The following is a description of a gene set: from publication Chen Y, Wang X (PMID 31504780) species: Mus musculus Mouse Gene Set: MIR_487B_3P Genes predicted to be targets of miRBase v22 microRNA mmu_miR_487b_3p in miRDB v6.0 with MirTarget v4 prediction scores > 80 (high confidence targets)., and this is the list of marker genes: Nsmf, Glcci1, Il33, Cep192, Nrarp, Prkca